Given this list of marker genes DOCK1, SRC (NCBI Gene Id 6714), DCC, FYN, WASL, NTN1, CDC42, ABLIM1, ABLIM2, PTK2, ABLIM3, RAC1, NCK1, TRIO, here is a description of the gene set: Human Gene Set: REACTOME_DCC_MEDIATED_ATTRACTIVE_SIGNALING species: Homo sapiens DCC mediated attractive signaling